Given this list of marker genes SMPX, FXR1, SVIL, ANK2, AHNAK, DAG1, ANK3, PGM5, PLEC, KRT19, SYNM, HOMER1, VCL, DMD, SDC4, FLNC, here is a description of the gene set: studied in species Homo sapiens Regular periodic sub membranous arrays of vinculin in skeletal and cardiac muscle cells, these arrays link Z-discs to the sarcolemma and are associated with links to extracellular matrix. Human Gene Set: GOCC_COSTAMERE